The following is a description of a gene set: Human Gene Set: GOBP_AMINO_ACID_BETAINE_BIOSYNTHETIC_PROCESS species: Homo sapiens The chemical reactions and pathways resulting in the formation of any betaine, the N-trimethyl derivative of an amino acid., and this is the list of marker genes: BBOX1, ALDH9A1 (aldehyde dehydrogenase 9 family member A1), ALDH7A1, TMLHE, CHDH, SHMT1, ACADM